Given this list of marker genes Atf7, Per3, Srebf1, Med1, Hdac5, Gata4, Creb1, Crebbp, Rxra, Hes1, Gata3, Smarca4, Flywch1, Hdgf, Sp1, Ppara, Nek6, Ehmt1 (NCBI Gene Id 77683), Fos, Hand2, Hmga1, Nr1d1, Hdac6 (NCBI Gene Id 20374), Myc, Pax6, Cdc5lrt8, Ar, Trappc2b, Baiap2, Ube2i, Pparg, Cdc5l, Rara, Gata2, Zbtb16, Six3, Smad4, Rpl23, Foxo1, Cdc37, Nr5a1, Zbtb49 (NCBI Gene Id 75079), Rora, Hnf4a, Ctbp2, Med6, Wiz, Foxp2 (forkhead box P2), Zbtb17, Bsn, Lmo2, Ehmt2, Gata6, Pbx1, Cbx3, Nr5a2, Fam89b, Lef1, Zfp644, Smarcd3 (NCBI Gene Id 78383), Ahr, Mtf2, Med25, Stk36, Rorc, Nkx2-1, Zfp568, Hmga1b, Cdc5lrt10, Trappc2, Nfya, Ppard, Cdc5lrt5, Six1, Klf4, Vgll4, Epas1, Trp53, Phf12, Cdc5lrt1, Nr3c2, Hdac2, Hdac1, Ccnt2, Bmyc, Stat6, Cit, Eno1, Nr1h4, Eed, Foxo3, Foxp1, Lhx3, Jund, Atxn3, Zbtb8a, Eno1b, Ctnnb1, Tert, Trerf1, Thrb, Smad3, Runx3, Usp11, Esr1, Suz12, Cdc5lrt9, Creb3, Trp73, Lcor, Gata1, Hdac3, Bcl6, Ctbp1, Ep300, Ets1, Elob, Cdk9, Hnf1b, Zfp618, Hand1 (NCBI Gene Id 15110), Stat1, Pax3, Eloc, Hif1a, Cdc5lrt6, Rela, Runx1, Zbtb7a, Ezh2, Per2, Phf1, Ctcf, Nfatc1, Hnf1a, Twist1, Tfam, Thap7, Per1, Nfe2l2, Cdc5lrt7, Map3k7, Chd6, Cnot2, Chd4, Cdc5lrt4, Pgr, Pclo, Tead2, Nr4a3, here is a description of the gene set: species: Mus musculus Mouse Gene Set: GOMF_TRANSCRIPTION_COREGULATOR_BINDING Binding to a transcription coregulator, a protein involved in regulation of transcription via protein-protein interactions with transcription factors and other transcription regulatory proteins. Cofactors do not bind DNA directly, but rather mediate protein-protein interactions between regulatory transcription factors and the basal transcription machinery.